The following is a description of a gene set: studied in species Mus musculus Catalysis of the reaction: 5-alpha-androstane-3-beta,17-beta-diol + NADP+ = 17-beta-hydroxy-5-alpha-androstan-3-one + H+ + NADPH. Mouse Gene Set: GOMF_5_ALPHA_ANDROSTANE_3_BETA_17_BETA_DIOL_DEHYDROGENASE_NADPPLUS_ACTIVITY, and this is the list of marker genes: Hsd17b7, Hsd3b1, Hsd17b6 (NCBI Gene Id 27400), Hsd3b5, Akr1c21, Hsd3b4